Given this list of marker genes TRADD, RAB4B, IQGAP1, WDR19, STAG1, NME7, LRRC39, ZNF25, DNAJC13, MAVS, KLHL8, LIPT2-AS1, ATE1, CSK, CSTPP1, PHKB (NCBI Gene Id 5257), IFRD2, DALRD3, NBAS, STK3, SRPK1, IL18RAP, BANF1, ZFP3, IQCE, RHOT1, NELL2, TBC1D22A, RHBDD1 (rhomboid domain containing 1), WDR59, RAB3IP, RNASEH2A, MIPEP, C10orf143, TTN, AZI2, EGR3, MPP7, NRDC, AFG2A, WDR90, EFCAB14 (NCBI Gene Id 9813), CHID1, GSTCD, WASHC3, ZMYM4, CROT, TMEM161A, CCDC191 (coiled-coil domain containing 191), CARS2, USP33, FBXO4 (NCBI Gene Id 55087), CBR4, PKP4, DROSHA, ZNF37BP, SLC66A3, LRFN3, CCDC14, TEP1, NDUFAF2, WWC3, PIGN, KIAA0319L, ATP5MC1, CETN2, TIMELESS, KAT2B, CUL4B, ZNF239, RALB (RAS like proto-oncogene B), EXOC2, ABCB10, TMEM80, ARHGEF6, TSEN2, TRPT1, ABRAXAS1, ZFC3H1, MYBL1, HECTD4, DECR1, OIP5-AS1, AHCYL2, CATSPERB, DPH3, DOCK10, SLC4A2 (solute carrier family 4 member 2, NCBI Gene Id 96677), AFF1, TIA1, LINC01138, PTGER2 (NCBI Gene Id 63381), GALT, ENKD1, VAMP4, AKT1, FLOT1, CENPJ, HSD17B8, COMMD8, PPM1F, USP32, C11orf54, DOCK8, MDM1 (Mdm1 nuclear protein), SPG11, MCCC1, RAB3GAP2, ATR (ATR serine/threonine kinase), TXK, ASB16-AS1, IFT43, FOCAD, C18orf54, FAHD2A, HERC4, KMT5B, PPARA, DNPH1, EHBP1, CHD9 (NCBI Gene Id 80205), TAF6, PSME2, RIOX2, TCF12, EGR1, CDK19, ANKS1A, LNPK, DYNLT2B, PHF14, SLX4, ITPR1, TASOR, IPO8, IFNG, FANCI, EPRS1, TAPBPL, ZNF80, TM7SF3, NFYB, MTIF3, ZMYM6, DPAGT1, TMEM131, PTRH1, TMX3, SLF2, PDSS2, ZBTB40 (zinc finger and BTB domain containing 40), EXOC7, HSDL2, TMEM205, ZMYND11, PDE3B, ZNF514, POMGNT1, RNF123, SPRN, CEP41, GOLGA3, DNAAF5, RNF170, WDR70, NAPEPLD, PCCA, NUP107, ZNF512, FIG4, PIGG, PPP3CB, TRERF1, TSC1, MZF1, MEN1, TMEM218, DPP4, TIGD7, CDRT4, ERC1, TMED10, FLII, RMI1, AFG3L1P, GNPAT, UBQLN4, ALS2, CDPF1, FAM111A, MYH3, FAAP100, AP1G2, LINC01550, ALG6, RAPH1, RNF187, here is a description of the gene set: Triggering of B cell receptors (BCR) induces a massive synthesis of NFATc1 in splenic B cells. By inactivating the Nfatc1 gene and re-expressing NFATc1 we show that NFATc1 levels are critical for the survival of splenic B cells upon BCR stimulation. NFATc1 ablation led to decreased BCR-induced Ca++ flux and proliferation of splenic B cells, increased apoptosis and suppressed germinal centre formation and immunoglobulin class switch by T cell-independent antigens. By controlling IL-10 synthesis in B cells, NFATc1 supported the proliferation and IL-2 synthesis of T cells in vitro and appeared to contribute to the mild clinical course of Experimental Autoimmune Encephalomyelitis in mice bearing NFATc1-/- B cells. These data indicate NFATc1 as a key factor controlling B cell function. from publication Bhattacharyya S, Deb J, Patra AK, Thuy Pham DA, Chen W, Vaeth M, Berberich-Siebelt F, Klein-Hessling S, Lamperti ED, Reifenberg K, Jellusova J, Schweizer A, Nitschke L, Leich E, Rosenwald A, Brunner C, Engelmann S, Bommhardt U, Avots A, Müller MR, Kondo E, Serfling E (PMID 21464221) Genes down-regulated in B lymphocytes stimulated by anti-IgM: 3h versus 16h. Human Gene Set: GSE21063_3H_VS_16H_ANTI_IGM_STIM_BCELL_DN species: Homo sapiens